The following is a description of a gene set: Transcripts dependent upon IRS1 and IRS2 for normal expression in liver. Human Gene Set: GUO_TARGETS_OF_IRS1_AND_IRS2 from publication Guo S, Copps KD, Dong X, Park S, Cheng Z, Pocai A, Rossetti L, Sajan M, Farese RV, White MF (PMID 19596788) studied in species Mus musculus We used a Cre-loxP approach to generate mice with varied expression of hepatic Irs1 and Irs2 to establish the contribution of each protein to hepatic nutrient homeostasis. While nutrient-sensitive transcripts were expressed nearly normally in liver lacking Irs2 (LKO2 mice), these transcripts were significantly dysregulated in liver lacking Irs1 (LKO1 mice) or Irs1 and Irs2 together (DKO mice). Similarly, a set of key gluconeogenic and lipogenic genes was regulated nearly normally by feeding in liver retaining a single Irs1 allele without Irs2 (DKO/1 mice) but was poorly regulated in liver retaining one Irs2 allele without Irs1 (DKO/2 mice). DKO/2 mice, but not DKO/1 mice, also showed impaired glucose tolerance and insulin sensitivity-though both Irs1 and Irs2 were required to suppress hepatic glucose production during hyperinsulinemic-euglycemic clamp. In contrast, either hepatic Irs1 or Irs2 mediated suppression of HGP by intracerebroventricular insulin infusion. After 12 weeks on a high-fat diet, postprandial tyrosine phosphorylation of Irs1 increased in livers of control and LKO2 mice, whereas tyrosine phosphorylation of Irs2 decreased in control and LKO1 mice. Moreover, LKO1 mice -- but not LKO2 mice -- that were fed a high-fat diet developed postprandial hyperglycemia. We conclude that Irs1 is the principal mediator of hepatic insulin action that maintains glucose homeostasis., and this is the list of marker genes: PPP1R3B, MXI1, IGFBP1, CTSV, GFRA1, GNS, ABCB4, HMGA1, ELK4, AGTR1, HSPH1, PPARGC1A, SIRT3, MVD, HSP90AA1, PCBP4, DNAJA1 (NCBI Gene Id 4737), RBPMS, CACYBP, SQLE, NUDT4, ATXN2, FDFT1 (farnesyl-diphosphate farnesyltransferase 1), IFI35, LBHD1, CEBPB, IL6R, ABCG8, PCK1, DNAJB2, RND1, SC5D, PDE7B, G6PC1, GCK, SGK2, SLC7A2, CCNI (NCBI Gene Id 10983), CASP6, TM4SF4, ACAT2, CDC34, CYP51A1, ARHGAP5, NFE2, RBMS1, INSR, DKC1, GRN, CTPS1 (CTP synthase 1), ABCG5, NUDT7, DHCR24, TAOK3, PPP3CA, KLF9, BCL3, CRYBG1, LSS, RBM39, MVK, PPM1A, NSDHL, GEMIN2, TUBB, MSMO1, BYSL, PPARGC1B, HMGCR, GALNT2, FDPS, DHCR7, MOGS (mannosyl-oligosaccharide glucosidase), RBL2, AFF4, TNFRSF1B, TAT, TUBB4B (NCBI Gene Id 10383), CDIP1, ECI2 (NCBI Gene Id 134779), LPP, ACACA, FUS, PCSK9, GNE, SCARB1, GK (glycerol kinase), NIPBL, CPT1A, PROK1, NR1I2, ACTB, GCH1, RCAN1, PITPNC1, SYT1